Given this list of marker genes RPS24 (NCBI Gene Id 6229), CPOX, FASLG, MTTP, RPL35, FANCC, BCL11A (BCL11 transcription factor A), TSR2 (NCBI Gene Id 90121), RPL27, RPS29, IFNG, RPL31, GCLC, PKLR, RHCE, RHD, FAS, CASK (NCBI Gene Id 8573), RPS7 (NCBI Gene Id 6201), KCNN4, KLF1, PRF1, CLCN7, RPL8, PGK1, RPS19, FANCA, NT5C3A, RPS10, FANCD2, EPB41, HBG2, UROS, RPS17, ABCG8, CFH, CUBN, PIEZO1, EPB42, ADA2, RPS20, RPL18, AMN, RPL35A, PIGA, G6PD, HEATR3, CDAN1, ABCB6, FANCE, SPTB, GATA1, TERC (NCBI Gene Id 7012), SBDS, RPL26, RPL9, TERT, GYPC, RPS26, ADAMTS13, HBB, RPS27, TCN2, SPTA1, STEAP3, GALE, CFHR3, MYSM1, NHLRC2, HBG1, ANK1, RPL11 (ribosomal protein L11), RHAG, RPL5, SEC23B, SLC4A1, CDIN1, PFKM, CASP10, CFHR1, RPS15A, RPS28, RPL15, SLC2A1, HK1, here is a description of the gene set: studied in species Homo sapiens A reticulocyte abnormality. Abnormal reticulocyte morphology Human Gene Set: HP_ABNORMAL_RETICULOCYTE_MORPHOLOGY